Given this list of marker genes Prap1, Mttp, Apoh, Cd36, Lpcat3, Dennd5b, here is a description of the gene set: Mouse Gene Set: GOBP_ACYLGLYCEROL_TRANSPORT species: Mus musculus The directed movement of an acylglycerol into, out of or within a cell, or between cells, by means of some agent such as a transporter or pore. An acylglycerol is any mono-, di- or triester of glycerol with (one or more) fatty acids.